Given this list of marker genes Enpp1, Alpl, Hnrnpa1, Slc26a5, Edn1, Abcc6, Nefh, Nefl, Hsf1, Slc34a1, Atg7, Mapk13, Slc12a3, Phex, Tgfb1, Rnls, Ednrb, Zc3h12a, Grp, Comt, Fgf23, Hnrnpd, Daxx, Npr2, Ank, Fgfr3, Lonrf2, Fgfr1, Runx2, here is a description of the gene set: Mouse Gene Set: GOBP_RESPONSE_TO_SALT Any process that results in a change in state or activity of a cell or an organism (in terms of movement, secretion, enzyme production, gene expression, etc.) as a result of a salt stimulus. species: Mus musculus